Given this list of marker genes ICOS, PHLPP1, IDO1, FOXP3, ITCH, HLA-G, CD3E, LILRB2, CLC, NR5A2, HLA-B, IL2RA, TGFBR2, LILRB4, CBLB, AIRE, here is a description of the gene set: A process involving any mechanism for tolerance induction in T cells. studied in species Homo sapiens Human Gene Set: GOBP_T_CELL_TOLERANCE_INDUCTION